Given this list of marker genes DEPDC1, CLIC4, TNFRSF9, IFITM1, KLRC2, EPAS1, SYTL3, RPA2, SNX10, TRIP13, RGS1, CARHSP1, CWC15, RAN, GYG1, CALM3, CEP57, SPC24, CTLA4, NCAPH, NME1, APOBEC2, CDCA8, HMGN2, GSAP, GTF2F2, CENPH, CCDC34, PGK1, RAD18, HAT1, AIF1, GADD45B, CLIC1, TXNDC17, NKG7, SNX5, MYL4, ITGAX, NFIL3, LAMP2, NDUFC2, SNRPB2, LILRB4, GIMAP7, H1-0 (NCBI Gene Id 3005), NCALD, PRELID1, SNRPD1, FIGNL1, HAVCR2 (NCBI Gene Id 84868), CDC14A, COX17, MPHOSPH6 (NCBI Gene Id 10200), HAUS4, ZDHHC2, KIF11 (NCBI Gene Id 3832), INSL6, CCDC50, SYPL1, PRR11, ATP5IF1, OSBPL3, SMPDL3B, NDUFA12 (NCBI Gene Id 55967), CXCL10, MYADM, ESM1, PSMD8, NRM, IFITM3, PRIM1, CALM1, SYCE2, PLAC8, PSMC3IP, LAMC1, CASP1, GABARAPL1, ARF6, RBBP8, ERH, MAD2L1, MED7, RNF216, IFI16, ATF6, GCNT1, NDUFS6, TMEM163, DSTN, COX5A, SERPINB9, LDHA, HPRT1, ALCAM, GINS1, CHST11, LAIR1, PHLDA1, ATP5F1C, IRF4, PPP1CC, H2AZ1, ID2, ACTG1, ACOT7, MKI67, DSCC1, LIG1, UFC1, PTMS, RAP2A, CCZ1, ANXA1, PSMA1, EMP1, GGH, ETFB, BEX3, PSMA5, DERA, CIAO2A, CD24, HMGN3, SLAMF7, PSMD12, PMAIP1, ROM1 (retinal outer segment membrane protein 1), PSMA6, ACADL, RAD51, BATF, PSMB2, VIM, YBX3, NIBAN1, BUB1, KLF11, NR4A1, STMN1, ADPRH, TXN, PRR13, RYK, FKBP2, SAR1B, UBE2N, H2BC4, PRDM1, ARSB, COPS4, KIF15, IL12RB2, FOSB, SPC25, DBI, NLN, SCRN3, RILPL2, EFHD2, CRIP1, ANAPC13, PHF11, GLRX, KLRK1, TACC3, SNF8, UXS1, GEM, TXNL1, MIS18BP1, GMDS, CD44, S100A9, COPS5, TCEAL9, RFC3, here is a description of the gene set: species: Homo sapiens Human Gene Set: GSE13547_WT_VS_ZFX_KO_BCELL_DN The development, homeostasis and function of B lymphocytes involve multiple rounds of B cell receptor (BCR)-controlled proliferation and prolonged maintenance. We analyzed the role of transcription factor Zfx, a recently identified regulator of stem cell maintenance, in B cell development and homeostasis. Conditional Zfx deletion in the bone marrow blocked B cell development at the pre-BCR selection checkpoint. Zfx deficiency in peripheral B cells caused impaired generation of the B-1 cell lineage, accelerated B cell turnover, depletion of mature recirculating cells, and delayed T-dependent antibody responses. Zfx-deficient B cells showed normal proximal BCR signaling, but impaired BCR-induced proliferation and survival. This was accompanied by aberrantly enhanced and prolonged integrated stress response, and delayed induction of Cyclin D2 and Bcl-xL proteins. Thus, Zfx restrains the stress response and couples antigen receptor signaling to B cell expansion and maintenance during development and peripheral homeostasis. from publication Arenzana TL, Smith-Raska MR, Reizis B (PMID 19329779) Genes down-regulated in B lymphocytes: wildtype versus ZFX.